Given this list of marker genes ENPP7, CCN1, ZNF750, SIRT3, PLA2G6, PRKCD, SPHK2, here is a description of the gene set: studied in species Homo sapiens Human Gene Set: GOBP_POSITIVE_REGULATION_OF_SPHINGOLIPID_BIOSYNTHETIC_PROCESS Any process that increases the rate, frequency or extent of sphingolipid biosynthesis. Sphingolipid biosynthesis is the chemical reactions and pathways resulting in the formation of sphingolipids, any of a class of lipids containing the long-chain amine diol sphingosine or a closely related base (a sphingoid).